The following is a description of a gene set: electronically inferred by orthology from the curated human pathway species: Mus musculus part of: HDR through Homologous Recombination (HRR) or Single Strand Annealing (SSA) Reactome Pathway: HDR through Single Strand Annealing (SSA) This event has been computationally inferred from an event that has been demonstrated in another species.<p>The inference is based on the homology mapping from PANTHER. Briefly, reactions for which all involved PhysicalEntities (in input, output and catalyst) have a mapped orthologue/paralogue (for complexes at least 75% of components must have a mapping) are inferred to the other species., and this is the list of marker genes: Lig1, Ercc4, Mre11a, Blm, Rpa1, Brca1 (breast cancer 1, early onset), Rad1, Hus1, Dna2, Rad52, Rfc3, Wrn, Bard1, Rbbp8, Kat5, Nbn, Top3a, Rad9a, Ercc1